The following is a description of a gene set: species: Mus musculus Mouse genes annotated to HALLMARK_KRAS_SIGNALING_UP based on orthology mappings provided by the Alliance Genome Consortium from publication Howe DG, Blake JA, Bradford YM, Bult CJ, Calvi BR, Engel SR, Kadin JA, Kaufman TC, Kishore R, Laulederkind SJF, Lewis SE, Moxon SAT, Richardson JE, Smith C (PMID 30224793) Mouse Gene Set: HALLMARK_KRAS_SIGNALING_UP, and this is the list of marker genes: Dusp6, Mmp9, Dcbld2, Tmem176b (transmembrane protein 176B), Ets1, Cdadc1, Ctss, Spry2, Cfb, Zfp277, Hdac9, Arg1, Clec4a3, Itgb2, Lat2, Atg10, Dnmbp (NCBI Gene Id 71972), Ano1, Snap91, Plau, Tnfrsf1b, Csf2, Gfpt2 (glutamine fructose-6-phosphate transaminase 2), Trib1, Prrx1, Map3k1, Vwa5a, G0s2, Crot, Klf4, Psmb8, Etv4, Rgs16, Strn, Sema3b, Il1rl2, Tnnt2, Tph1, Fuca1, Fgf9 (fibroblast growth factor 9), Plvap, Bpgm, Ammecr1, Cbx8, Btc, C3ar1, Mmp10, Traf1, Il7r, Sparcl1, Jup, Cbl, Prkg2, Tnfaip3, Reln, Cxcr4, Fbxo4 (F-box protein 4), Angptl4, Irf8, Scg5, Scg3, Snap25, Car2, Glrx, Flt4, Abcb1a, Igfbp3, Kif5c, Akt2, Adgra2, Il10ra (interleukin 10 receptor, alpha), Nrp1, Lif, Wdr33, Ccser2, Csf2ra, Nr0b2, Tspan7, Kcnn4, Tfpi, Prelid3b, Apod, Cfh, Ero1a, Nap1l2, Mall, Il33, Pcp4, Spp1, Usp12, Btbd3, Id2, Ccl20, Avl9, Akap12, Tlr8, Hbegf (heparin-binding EGF-like growth factor), Plaur, Ptprr, Gypc, Il2rg (NCBI Gene Id 16186), Pdcd1lg2, Zfp639, Ppp1r15a, Gadd45g, H2bc3 (NCBI Gene Id 319178), Yrdc, Peg3, Retn, Cd37, Eng, Wnt7a, Map7, Plek2, Pecam1, Mpzl2, Bmp2, Evi5, Gpnmb, Sox9, Itga2, Pcsk1n, Scn1b, Cxcl10, Slpi, Emp1, Tor1aip2, Satb1, Etv5, Etv1 (NCBI Gene Id 14009), Il1b, Map4k1, Adgrl4, F13a1, Gabra3, Adam8, Lcp1, Cidea, Anxa10, Galnt3, Ikzf1, Dock2, Ereg, Ccnd2, Birc3, Mycn, Adamdec1, Ly96, Ngf, Adam17, Tspan13, Sdccag8, Mmd, Nr1h4, Ush1c, Prdm1, St6gal1, Spon1, Aldh1a3, Aldh1a2, Epb41l3, Ptcd2, Gprc5b, Inhba, Cab39l, Hkdc1, Tmem176a, Cmklr1, Gng11, Nin, Ppbp, Igf2, Laptm5, Mafb, Pigr, Rbp4, Tspan1, Ephb2, Gucy1a1, Ace, Hsd11b1, Tmem100, Rbm4, Plat, Ptgs2, Itgbl1, Hoxd11, Rabgap1l, Ptbp2, Ank, Fcer1g, Mtmr10, Cpe, Cbr4, F2rl1 (F2R like trypsin receptor 1), Tmem158, Mmp11, Trib2